Given this list of marker genes Mei1, Terf1, Spo11, Xrcc5, Mlh1, Ube2b, here is a description of the gene set: The cell cycle phase which is the first stage of prophase I in meiosis, and during which the chromosomes first become visible. species: Mus musculus Mouse Gene Set: GOBP_LEPTOTENE